The following is a description of a gene set: Human Gene Set: HP_ABNORMAL_URINE_CARBOXYLIC_ACID_LEVEL studied in species Homo sapiens Any deviation from the normal concentration of a carboxylic acid in the urine. Abnormal urine carboxylic acid level, and this is the list of marker genes: PAH, MICOS13, UMPS, MMUT, ALDH4A1, SUGCT, FBXL4, MMADHC, ATAD3A, ATP5F1A, AGK, PRDX1 (peroxiredoxin 1), COX16, RET (ret proto-oncogene), IDH2, CPOX, KIF1B, ALDH5A1, NGLY1, AUH, MLYCD, NDUFS4, SLC25A20, TMEM70, ACADS, UROS, ECHS1, ASS1, PCCB, SLC13A3 (solute carrier family 13 member 3), CAD, SUCLG1, SLC25A15, SLC18A2, KYNU, ACADSB, CA5A, ACADVL, FDFT1, HSPD1, BCKDHA, FOCAD, SLC52A1, ACAD9, HMBS, POLG, ARG1, D2HGDH, HLCS, ETFB, DNAJC19, MMACHC, MTR, IDH1, HADH, TAT, ATP5F1D, MRPL39, HACE1, GRHPR, ACAD8, GCDH, MT-ATP8, SLC25A1, MTRR, FH, MVK, HMGCS2, HGD, TRMU, SCO1, SFXN4, ATP5F1E, ASL, TAMM41, ALK, OPA3, ACADM, MCEE, SLC22A5, FTCD, HCFC1, SLC6A19, DDC, CPT2, LMBRD1, ATP5MK, ABCD4, CD320, PHOX2B, SLC7A7, HMGCL, NDUFB10, ACSF3, LETM1, ALDH6A1, HTRA2, LIN28B, ETFDH, UPB1, HPD, SDHA, COQ4, L2HGDH, CPT1A, DHTKD1, MYCN, ALAD, MCCC1, MMAA, OXCT1, TFAM, MMAB, ATPAF2, OTC, SUCLA2, MT-ATP6, CLPB, TIMM50, FDX2, TAFAZZIN, ETHE1, AGXT, PCCA, LMO1, GATA1, PEX14, ETFA, NFU1, SERAC1, TCN2, UROC1, MT-TL1, PPOX